Given this list of marker genes Myf6, Myh1, Notch1, Hif1an, Mapk14, Hif1a, Myog, Bhlhe40, Myf5, Cdkn1a, Vegfa, Egln1 (NCBI Gene Id 66006), Cdkn1b, here is a description of the gene set: Mouse Gene Set: WP_HYPOXIADEPENDENT_DIFFERENTIATION_OF_MYOBLASTS studied in species Mus musculus Hypoxia-dependent differentiation of myoblasts